The following is a description of a gene set: Any process that modulates the frequency, rate or extent of neuron differentiation. studied in species Homo sapiens Human Gene Set: GOBP_REGULATION_OF_NEURON_DIFFERENTIATION, and this is the list of marker genes: FGF20, NR2E1, GDF11, HMG20A, ID4, CNTN2, FGFR1, BMP4, FOXG1, ISL1, RAB37, DKK1, ITGB1, SIN3A, SOX2, RELN, BCL11A, DLL1, BCL11B, EIF4ENIF1, BCL6, ZFHX2, CNTF, MMD2, FOXA1, WNT3A, EIF4E, TCF3, NAP1L2, MAP1B, LRRK2, BIN1, MMD, SIX3, GPRC5B, MAG, MAP3K13, ZFHX3, ARHGEF2, GLI3, ALK, HES1, CYB5D2, DISP3, MEF2C, NCOA1, GSK3B, TUNAR, NRCAM, OLIG2, KCTD11, ZNF536, ADRA2B, DLX2, VWC2, TP73, MICOS10-NBL1, BNIP2, EDNRB, RNF112, BRINP3, APP, NOTCH3, TRPC6, DIXDC1, ASCL1 (NCBI Gene Id 429), IRX3, NEUROG1, PHOX2B, ROCK1, LBX1, SOX9 (NCBI Gene Id 6662), FERD3L (NCBI Gene Id 222894), SFRP1, RHOA, LTK, YWHAH, PAX6, BRINP1, EYA1, CDK5RAP2, UPF3B, MYCL, YWHAG, ADRA2C, CTDSP1, HMG20B, SOX3, CALR, ID2 (NCBI Gene Id 3398), HES5 (NCBI Gene Id 388585), FOXO3, WDR62, SLC6A4, CDK5RAP1, SPAG9, GDF5, CASZ1 (NCBI Gene Id 654487), BMP6, TBX6, METTL14, SOX11, ZC4H2, TLX3, RAC1, POU4F2, DUOXA1 (NCBI Gene Id 90527), DMD, LSM1, NKX6-3, MIR511 (microRNA 511), NREP, FEZF2, EIF4G1, FEZF1, RAC3, ECT2, BMP2, MIR146A, PCP4, CNTN4, JAG1, BEND6, PROX1, SHOC2, HEY1, CDON, PTBP1, HEYL, SH3GL3, TIAM1 (TIAM Rac1 associated GEF 1), MYCN, TRIM32, CXCL12, SOX8, ATOH1, NKX2-2, SOCS2, MOSMO, ASPM, S100B, FGF2, IMPACT, ESRP1, DAB1, GDF6, TCF4, PBX1, MED1, HEY2, SIX1, DDX6, GPR37L1, TGIF1, NEUROD1, ZHX2, CPNE1, BRINP2, RAP1GAP, GDPD5, REST, BMP7, RARA, EIF2AK4 (NCBI Gene Id 440275), DLX1, TRPC5, FUOM, LIN28A, HOXD3, NGF, NEUROG3, BCL2, CDK5RAP3, LMX1A, ZEB1, CDK5R1, EPO, NBL1, ETV5, MIB1, NEPRO, ISL2, NKX6-1, MEIS1, TCF12, NEUROD2, SFRP2, VWC2L, GDF7, NKX2-5, TGIF2, MIR137, GATA2, NOTCH1, HOXA2, B2M, SHH, NLGN1, DTX1